Given this list of marker genes GATA4, FOXF1, IHH, SHH, BMP4, here is a description of the gene set: Human Gene Set: REACTOME_FORMATION_OF_LATERAL_PLATE_MESODERM Formation of lateral plate mesoderm species: Homo sapiens